The following is a description of a gene set: Mouse Gene Set: GOBP_EPITHELIAL_FLUID_TRANSPORT The directed movement of fluid across epithelia. species: Mus musculus, and this is the list of marker genes: Scnn1b, Aqp8, Edn1, Ahcyl1, Slc26a6, Itpr1, Ednrb, Cldn18, Cftr, Pkp1, Aqp1, Csf2, Slc5a1